The following is a description of a gene set: Mouse Gene Set: GOMF_RNA_POLYMERASE_II_CTD_HEPTAPEPTIDE_REPEAT_Y1_KINASE_ACTIVITY studied in species Mus musculus Catalysis of the reaction: ATP + RNA polymerase II large subunit CTD heptapeptide repeat (consensus YSPTSPS) = ADP + H+ + RNA polymerase II large subunit phosphotyrosine (position 1)., and this is the list of marker genes: Cdk8, Cdk7, Cdk1, Cdk9, Cdk13, Cdk12